The following is a description of a gene set: Human Gene Set: GOBP_PROTEIN_TO_MEMBRANE_DOCKING The initial attachment of a protein to a target membrane, mediated by a proteins protruding from the target membrane. Docking requires only that the proteins come close enough to interact and adhere. studied in species Homo sapiens, and this is the list of marker genes: STXBP3, RAB7A, PEX16, SNX3, PEX26